The following is a description of a gene set: Human Gene Set: GOBP_TERPENOID_METABOLIC_PROCESS The chemical reactions and pathways involving terpenoids, any member of a class of compounds characterized by an isoprenoid chemical structure and including derivatives with various functional groups. species: Homo sapiens, and this is the list of marker genes: ADH1C, AWAT2, CYP2C9, UGT1A3 (UDP glucuronosyltransferase family 1 member A3), AKR1C3, CYP1A1, TTR, CYP2C18, UGT1A8, LSS, DHRS4, ALDH8A1, RBP4 (NCBI Gene Id 5950), LRP8 (LDL receptor related protein 8), PLPP6, PNPLA2, DHRS4L2, BCO1, RBP3, RPE65, CYP1A2, CLPS, PECR, ADH1A, CYP1B1, RDH12, CYP26B1, HMGCS1, RDH13, CYP26C1 (NCBI Gene Id 340665), CYP2W1, CRABP2, PLB1, GGPS1, CYP3A4, LRAT, BCO2, ADH1B, CYP2C19, FDFT1, RLBP1, RETSAT, UGT1A1, CYP3A7, SRD5A1, RBP1 (retinol binding protein 1), CYP2D6, HMGCS2, DHRS9 (dehydrogenase/reductase 9), ADH4, DGAT2, DGAT1, CYP2E1, LRP1, UGT1A9, PRMT3, RDH11, CYP2S1, RDH5 (NCBI Gene Id 81991), CYP2C8 (NCBI Gene Id 1558), ALDH1A3, RDH14, LDLR, AKR1B1, RBP2, CYP4V2 (NCBI Gene Id 64587), SDR16C5, HSD17B6, CYP27C1, LRP2, AKR1B10, SCPEP1, HTRA2, DHRS4L1, ADH6, DHRS3, RDH10, CYP3A5, ALDH3A2, FDPS, RDH8, LPL, ADH7, RDH16, CYP26A1, PNPLA4, ALDH1A2, AKR1B15, AKR1C4, PNLIP, ALDH1A1, ABCA4, LIPE, CRH, AKR1C1, DHRS7, RARRES2, ADH5, LIPA, UGT1A7, SDR9C7, CEL